Given this list of marker genes CSRP1 (cysteine and glycine rich protein 1), SLC44A1, SPSB4, SNTB2 (NCBI Gene Id 6645), BCAS3, CD300LF, BFAR, ELF1, GUK1, WASHC4, TMEM176B, CH25H, TAF1B, NRDE2, HELZ2, RBM7, MINK1, ARF5 (NCBI Gene Id 381), NCOA3, HES6, GLTP, H2AC25, STARD3, FLT1, HBEGF, MAF1, NAPSA, TOB1, CDC37, BRI3, ZNF740, SEPTIN10, MAFB, SIM1, UROD, MAPK9, CAMLG, MS4A1, FBXO4, RPS21, MICU1, MUL1, PLSCR3, VIM, TBC1D13, SAT1, MLF2, ZBTB11-AS1, DIO2, GMPPB, FABP5, LAT2, FGB, SNX2, KDR, STAG2, NUDT13, RBCK1, SOX11, TLR3, FAM110C, DCUN1D1, ING2, ST14, PLPP2, NAT1, ALDH1B1, ACTRT1, RASA3, CD300A, KDM3B, HSPA4L, IL12RB2, ECE2, TLE2, TANGO2, CASP4, PAXBP1 (NCBI Gene Id 94104), ARF4, PDE6D, PAG1, APOOL, MX2, RFX5, PXMP2, TPRA1, DAP, TSC22D3, PCYT1A, NTS, NKX3-2, TOR2A, PTTG1, NRTN, BCL2L14, MTHFR, S100A11, SLC25A3, UBE2B, CAAP1, MGST2, CERT1, DPEP3, TEX9, SULT1A1, CLIP1, CA4, SIX1, ZNF704, GCA, VEGFA, ERGIC3, FEZ2, CYS1, THNSL1, CARMIL1, TMEM184B, PRXL2A, SPINT2, SHFL, IRF1, EMC8, SH3TC1, H2AZ1, TMEM37 (NCBI Gene Id 50627), PLGRKT, PIK3CD (NCBI Gene Id 5293), GPNMB, NAAA, CCDC92, TMEM51, TRIOBP, CCDC136, ASB11, ZYG11B (zyg-11 family member B, cell cycle regulator), MYD88, EGR1, LTC4S, RNH1, ATP13A2, ASF1A, FBXO21, NCOA1, PACC1, PGLYRP1, HBP1, PRDM9, NFIL3, MED11, GLIPR2, CLK3, AP3B1, PTEN, SFT2D1, MX1, NSUN4 (NCBI Gene Id 387338), STX3, CHCHD7, LAPTM5, RBM25, PCP4, KLHL9, KLRK1, SGIP1, ITGB7, RHOC, MOCOS, TXNDC16, SLC35A5, TNFSF10, LASP1, SPTLC2, DGLUCY, SCT, GJC2, ATP5IF1, KAT2B, ENKD1, SLC12A9, TASOR2, KLF6, PCOLCE2, VGLL4, TNFRSF1A, CCNL2, TAF6L, BCAR3, TTYH2, RAD21, SORL1, PURG (NCBI Gene Id 29942), PRMT2, STAT4, ZNF444, TSPAN2 (NCBI Gene Id 10100), TMOD3, ANGPT1, DNASE1L3, RAB22A, ATP11B, here is a description of the gene set: mouse primary BMDCs were stimulated with tlr ligands and gene expression changes were profiled on Affymetrix arrays Human Gene Set: GSE17721_POLYIC_VS_CPG_12H_BMDC_UP Genes up-regulated in comparison of dendritic cells (DC) stimulated with poly(I:C) (TLR3 agonist) at 12 h versus DC cells stimulated with CpG DNA (TLR9 agonist) at 12 h. species: Homo sapiens from publication Amit I, Garber M, Chevrier N, Leite AP, Donner Y, Eisenhaure T, Guttman M, Grenier JK, Li W, Zuk O, Schubert LA, Birditt B, Shay T, Goren A, Zhang X, Smith Z, Deering R, McDonald RC, Cabili M, Bernstein BE, Rinn JL, Meissner A, Root DE, Hacohen N, Regev A (PMID 19729616)